The following is a description of a gene set: This event has been computationally inferred from an event that has been demonstrated in another species.<p>The inference is based on the homology mapping from PANTHER. Briefly, reactions for which all involved PhysicalEntities (in input, output and catalyst) have a mapped orthologue/paralogue (for complexes at least 75% of components must have a mapping) are inferred to the other species. studied in species Mus musculus part of: Inwardly rectifying K+ channels electronically inferred by orthology from the curated human pathway Reactome Pathway: Classical Kir channels, and this is the list of marker genes: Kcnj2, Kcnj14, Kcnj12